The following is a description of a gene set: species: Mus musculus Cytokines mediate cell-cell communication in the immune system and represent important therapeutic targets. A myriad of studies have highlighted their central role in immune function, yet we lack a global view of the cellular responses of each immune cell type to each cytokine. To address this gap, the authors created the Immune Dictionary, a compendium of single-cell transcriptomic profiles of more than 17 immune cell types in response to each of 86 cytokines (>1,400 cytokine-cell type combinations) in mouse lymph nodes in vivo. A cytokine-centric view of the dictionary revealed that most cytokines induce highly cell-type-specific responses. For example, the inflammatory cytokine interleukin-1β induces distinct gene programmes in almost every cell type. A cell-type-centric view of the dictionary identified more than 66 cytokine-driven cellular polarization states across immune cell types, including previously uncharacterized states such as an interleukin-18-induced polyfunctional natural killer cell state. Mouse Gene Set: CUI_CDC2_IL11_RESPONSE_UP from publication Cui A, Huang T, Li S, Ma A, Pérez JL, Sander C, Keskin DB, Wu CJ, Fraenkel E, Hacohen N (PMID 38057668) Genes positively differentially expressed in cell type: cDC2 (conventional dendritic cell type 2) upon treatment with cytokine: IL-11 in mouse lymph nodes in vivo., and this is the list of marker genes: Clec4n, Slc39a7, Ddx24, Nr1h3, Tspo, Fabp5, Ifnar2, Ftl1, Abi3, Gapdh, Cd300c2, Manf, Cfp, Tgfbi, Tspan4, Vsir, Lamtor4, Cdk2ap2, Rnh1, Lyn, Slc3a2, Lair1, Elob, Ssr2 (signal sequence receptor, beta), Atp5f1b, Il18, Rnf187